Given this list of marker genes KPNA1, NUP133, NUP35, SLC25A6, NUP98, NUP43, SEH1L, NUP42, POM121, NUP54, SLC25A5, NUP93, BANF1, POM121C, NUP85, NUP210, RAE1, NUP153, NUP58 (NCBI Gene Id 9818), NUP62, NUP160, NDC1, NUP205, NUP155, HMGA1, NUP37, NUP188, RANBP2, NUP88 (NCBI Gene Id 4927), NUP214, TPR, SEC13, AAAS, NUP50, PSIP1, SLC25A4, NUP107, here is a description of the gene set: species: Homo sapiens Human Gene Set: REACTOME_INTERACTIONS_OF_VPR_WITH_HOST_CELLULAR_PROTEINS Interactions of Vpr with host cellular proteins